The following is a description of a gene set: Mouse Gene Set: CUI_MONOCYTE_TNFA_RESPONSE_DN Cytokines mediate cell-cell communication in the immune system and represent important therapeutic targets. A myriad of studies have highlighted their central role in immune function, yet we lack a global view of the cellular responses of each immune cell type to each cytokine. To address this gap, the authors created the Immune Dictionary, a compendium of single-cell transcriptomic profiles of more than 17 immune cell types in response to each of 86 cytokines (>1,400 cytokine-cell type combinations) in mouse lymph nodes in vivo. A cytokine-centric view of the dictionary revealed that most cytokines induce highly cell-type-specific responses. For example, the inflammatory cytokine interleukin-1β induces distinct gene programmes in almost every cell type. A cell-type-centric view of the dictionary identified more than 66 cytokine-driven cellular polarization states across immune cell types, including previously uncharacterized states such as an interleukin-18-induced polyfunctional natural killer cell state. from publication Cui A, Huang T, Li S, Ma A, Pérez JL, Sander C, Keskin DB, Wu CJ, Fraenkel E, Hacohen N (PMID 38057668) Genes negatively differentially expressed in cell type: Monocyte upon treatment with cytokine: TNF-α in mouse lymph nodes in vivo. studied in species Mus musculus, and this is the list of marker genes: Fxyd5, F13a1, Atf3, Msrb1, Sirpb1c (signal-regulatory protein beta 1C), Gpx4, Selenop, S100a6, Ccr2, Fcgr3, Comt, Rnase6, AB124611, Macroh2a1, Tep1 (telomerase associated protein 1), Vim, Rsrp1, Hspa1b, Rassf4, Adgre1, Btg2, Ctsh, Fos, Cst3, Samhd1, Mrpl33, Hacd4, Fau, Cx3cr1, Pld4, Ypel3, Scand1, Anxa1, Sat1, Ccl6, Npc2, Lgals3, Celf2, Eef2, Eif3f, Ahnak, Tnfaip8l2, Plbd1, Esyt1, Higd2a, Jund, Ifitm6, H2az1, Tmsb10, Selplg, Ifi27l2a, Ly86, Psap, Klf2, Itgb7 (integrin beta 7), Coro1a, Ifitm3, Naca, Ctss, Crip1, Ptpn18, Hspa1a, Tmem50a, Cd48, Lamp1 (lysosomal-associated membrane protein 1), Mgst1, Alox5ap, Smpdl3a, Itm2b, Sptssa, Rgs2, Lyz2, Fosb, Taldo1, Ifngr1 (NCBI Gene Id 15979)